The following is a description of a gene set: Human Gene Set: GSE21063_WT_VS_NFATC1_KO_3H_ANTI_IGM_STIM_BCELL_UP Triggering of B cell receptors (BCR) induces a massive synthesis of NFATc1 in splenic B cells. By inactivating the Nfatc1 gene and re-expressing NFATc1 we show that NFATc1 levels are critical for the survival of splenic B cells upon BCR stimulation. NFATc1 ablation led to decreased BCR-induced Ca++ flux and proliferation of splenic B cells, increased apoptosis and suppressed germinal centre formation and immunoglobulin class switch by T cell-independent antigens. By controlling IL-10 synthesis in B cells, NFATc1 supported the proliferation and IL-2 synthesis of T cells in vitro and appeared to contribute to the mild clinical course of Experimental Autoimmune Encephalomyelitis in mice bearing NFATc1-/- B cells. These data indicate NFATc1 as a key factor controlling B cell function. species: Homo sapiens Genes up-regulated in B lymphocytes stimulated by anti-IgM for 3h: wildtype versus NFATC1 knockout. from publication Bhattacharyya S, Deb J, Patra AK, Thuy Pham DA, Chen W, Vaeth M, Berberich-Siebelt F, Klein-Hessling S, Lamperti ED, Reifenberg K, Jellusova J, Schweizer A, Nitschke L, Leich E, Rosenwald A, Brunner C, Engelmann S, Bommhardt U, Avots A, Müller MR, Kondo E, Serfling E (PMID 21464221), and this is the list of marker genes: KLK5, SERPINB8, PTPRK, TNFSF4, TP53INP1, VIPR2, RASGRP1, CD48, GPM6B, ASS1 (argininosuccinate synthase 1), EXOC4, C4orf17, CARTPT, LAG3, DLGAP1, UGT3A2, MON1A, BST1, HAO2, SEMA7A, SMC1B, MOV10, APOF, SGSH, SLC22A13, NDUFA7, ZNRD2, AOPEP, RFTN1, PRR5L, IBA57, PLK3, KRT73 (keratin 73), ADIPOQ, SLC38A3 (solute carrier family 38 member 3), PDE6B, KLRC1, RSPH14, SMARCB1, KCND1, C14orf180, MYO3B, WNT2, TIFA, SERTAD3, MXD1, AKR1B15, ZBTB38, FAM3C, NLRP5, SELENOP, TMEM71, PDE4A, SPACA1, CCDC198, SULF1, FILIP1L, UCP2, RNF180, USB1, DGLUCY, FCRL1, SLC6A8, GPR158, SNX1, PLEKHA7, NMB, CASP1, CCL28, AMN, CYP17A1, PLA2G10, DGKA, GDF15, MYCL, ANK1, ADPRHL1, MBLAC2, KCNMB2, MS4A6A, USP28, CCDC89, CRIP2, RANBP6, RGN (regucalcin), RNASE1, OSCAR, AK1, ANKRD16, UBE2L6, IL36G, NLRX1, CD96, VIL1, PRKAR2B, AZIN2, ARHGEF17, BPHL, CCDC102A, SLC4A10, CTSA, DUSP2, TMC7, PHLPP1, LYPD3, FOXG1, GUCY2C, ITGA4, NOXO1, GPNMB, MAPK8IP1, AAAS, CYP26B1, NUDT6, TSPY1, CD5 (NCBI Gene Id 921), KRT16, CD28, PGLYRP2, EGLN3, CXCR3, VMAC, GDF10, CASP6, FAM98C, B3GNT8 (UDP-GlcNAc:betaGal beta-1,3-N-acetylglucosaminyltransferase 8), FMO1, PTCHD1, LRRC3B, ATOX1, CCL4, BCL2L11, EPHX1, SLC20A2, LHB, TMBIM4, ALDH1A3, HOPX, BMP10, FAM162A, ABCA9, SBNO2, ALX3, TSPAN4, NRBP1, YPEL5, ARL4C, TFAP2E, GLRX, KIAA1549L, CIB4, PIK3AP1, RSPH9, PTPN14, TIMP1, SAMD9L, CNIH2, SLC34A2, SH3GL1, GPR161, SNX24, SPINK8, MST1, ADGRL4, GBP2, GFPT2, PPP3CC, ARF6, TRIL, SH3BGRL3, SKIDA1, FAM221B, HECW1, MYO9A, ARHGDIB, MBNL1 (muscleblind like splicing regulator 1), DNAJB12, SDS, TMEM41B, PPARA, SPP1, FOXO1, PLD3, NIPAL1, TBCD, VAMP1, SCRN2, NRSN1, ONECUT2, MAP1B, APOL6, TXNIP, SCARF1, MZB1, PLEKHG2, CPQ, TWIST1, GAB1, ELK4